Given this list of marker genes BABAM2, PEX5L, PEX7, PEX5, PEX19, here is a description of the gene set: Human Gene Set: GOMF_PEROXISOME_TARGETING_SEQUENCE_BINDING species: Homo sapiens Binding to a peroxisomal targeting sequence, a sequence of amino acids within a protein that acts as a signal for the localization of a protein into the peroxisome.